Given this list of marker genes Grb2, St8sia2, Hras, Fyn, Ptpra, Ptk2, Col6a1, Rps6ka5, Ncam1, Col6a5, Col2a1, Mapk3, Col4a2, Sptbn4, Col6a6, Col5a3, Sptbn2, Col9a1, St8sia4 (ST8 alpha-N-acetyl-neuraminide alpha-2,8-sialyltransferase 4), here is a description of the gene set: electronically inferred by orthology from the curated human pathway This event has been computationally inferred from an event that has been demonstrated in another species.<p>The inference is based on the homology mapping from PANTHER. Briefly, reactions for which all involved PhysicalEntities (in input, output and catalyst) have a mapped orthologue/paralogue (for complexes at least 75% of components must have a mapping) are inferred to the other species. part of: Axon guidance species: Mus musculus Reactome Pathway: NCAM signaling for neurite out-growth